The following is a description of a gene set: Genes predicted to be targets of miRBase v22 microRNA hsa-miR-526b-5p in miRDB v6.0 with MirTarget v4 prediction scores > 80 (high confidence targets). Human Gene Set: MIR526B_5P from publication Chen Y, Wang X (PMID 31504780) studied in species Homo sapiens, and this is the list of marker genes: TASOR, SLCO4C1, CREB1, TANC2, ANKRD42 (ankyrin repeat domain 42), NME6, DTX3L, NR1H4, FGD4, EPHB1, RNF217, ERLEC1, NLRC3, KIAA0319, RBL2 (RB transcriptional corepressor like 2), GNG10, PKP2, HDAC2, MKLN1, KLHDC1, PAFAH1B1, NSF, RAP1A, SCAMP1, MBNL3, HENMT1, ACTR3C, GRIK2, TAFA1, SLC13A4, GRIA4, PCP4, RPS6KA5, NDFIP1, LPL, HMG20A, PSME3, UBE2V2, LEPROTL1, SPTSSA, LPAR1, TMPRSS15, IDS, ACSS2, ALMS1, PHF6, PANK3, LRIF1, CWC27, NLGN1, LYPLA1, EXT2, AHCYL2, THAP6, NAP1L3, THBS1, ZNF124, DNAJC21, GCLM, AKAIN1, CASD1, RIMBP3B, FUT9, GABRG1, NPR3, NEDD4L, STAM, RIMKLB, TFPI, MTMR9, GABRG2, FKTN (fukutin), PDIA6, RPTN, ZFP91, RPRD1A, MLLT3, RARB, KTN1, UNC5C, SLC35F5, SH2D2A, ST13, APBB2, CR2, CHST15, CCDC157, WNK1, SRD5A3, PPHLN1, TBX21, VKORC1L1, HSD11B2, AGXT2 (alanine--glyoxylate aminotransferase 2), DNAJC25-GNG10, CPA6, PTPN14, SEMA5A, GFRAL, HHIP, CD200R1, CDKN2AIP, POU2F1